Given this list of marker genes NECTIN2, PVR, KLRD1 (NCBI Gene Id 92677), STAP1, SH2D1A, CD1B, CD5L, HLA-E, KLRC4, IL21, RASGRP1, MR1, HLA-C, HLA-DRB1, HLA-B, KLRC3, PTPRC, VAV1, MAPK8, F2RL1, TAP2, B2M, CD160, AZGP1, KLRC2, ARG1, STAT5A, RAET1E, HLA-G, HLA-F, TYROBP, SLAMF6, AP1G1, LAMP1, IL23R, CD226, FADD, CD1E, LAG3, PRF1, SLC22A13, STX7, HLA-A, RAET1G, NCR3, IL23A, STAT5B, XCL1, P2RX7, CYRIB, CD1A, CADM1, CD1C, ULBP2, POMC, HLA-H, ULBP1, NOS2, IL12RB1, IL18RAP, HLA-DRA (NCBI Gene Id 7930), RAET1L, KLRK1, KLRC4-KLRK1, IL12B, SPI1, IL12A (interleukin 12A), ULBP3, CD1D, KLRC1, CRTAM, ITGAM, here is a description of the gene set: studied in species Homo sapiens Any process that activates or increases the frequency, rate or extent of cell killing. Human Gene Set: GOBP_POSITIVE_REGULATION_OF_CELL_KILLING